The following is a description of a gene set: species: Homo sapiens Human Gene Set: E2F1DP2_01 Genes having at least one occurrence of the motif TTTSSCGC in the regions spanning 4 kb centered on their transcription starting sites. This matches the E2F1, TFDP2 transcription factor binding site V$E2F1DP2_01 (v7.4 TRANSFAC)., and this is the list of marker genes: THAP8, UNG, PAN2, TAOK2, PEG3, HNRNPUL1, MCM2, CORT, FKBP5, RET, RTBDN, GMNN, H2AC12, NELL2, SMC3 (structural maintenance of chromosomes 3), TMPO, POLE2, NFATC2IP, POLD1, GPRC5B, NOLC1, PRPS2, SOAT1, HMGXB4, IER5L, USP37, KBTBD7, RAVER1, PHF5A, PAX6, MAPK6, BRPF1, ADAMTS2, MCM3, MSH2, SYNGR4, DNAJC5G, TRMT6, OTUD7B, IPO7, MSH5, ZNF367, TBX6, NRK, DCTPP1, H3C1, E2F3, AP4M1, NASP, MCM8, CDC5L, MAP3K7, MCM6, STT3B, UBR7, PCNA, TRMT13, PCSK1, ILF3, E2F8, STAG1, MCMBP, NR6A1, DMD, POLD3, SPINK5, ARHGAP11A, PIM1, TOPBP1, PBRM1, CDCA7, PPIG, CBX3, KMT5A, ATAD2, AK2, KCNA6, ATF5, SPTB, ID3, MAZ, CAND1, DNAJC9, SASS6, MAPT, EZH2 (enhancer of zeste 2 polycomb repressive complex 2 subunit), CDK1, VCAN, YTHDC1, GABRB3, HS6ST3, EIF4A1, SNRPD1, EMSY, RASAL2, SMAD6, RPS20, RRM2, PRP4K, APH1A, PLAGL1, ZNF644 (zinc finger protein 644, NCBI Gene Id 90858), EFNA5, ALDH6A1, MXD3, ZNF524, FHOD1, ZCWPW1, SRSF1, MYH10, BRME1, NIPBL, GAPDH, ING3, NUFIP2, POLR2A, ASXL2, SMC6, FBXO5, GINS3, IL4I1, H2BC12, ZNF362, SP3, MYC, PKMYT1, GON7, NCL, UGGT1, MEPCE, MCM7, TMEM108, DNMT1, CDC25A, PPM1D, FANCG, JADE1, HNRNPA2B1, TMEM143, MRPL40, SEMA6A, RIBC1, EED, SLC9A5, SLC9A7, CASP8AP2, HMGA1, DLG3, YBX2, E2F7, HNRNPR, APPL1, TRIM39, POU4F1, TYRO3, SUMO1, HCN3, ARID4A, AP1S1, KCNS2, RPS6KA5 (NCBI Gene Id 9252), DCK, GEN1, PODN, RANBP1, CLSPN, BRMS1L (NCBI Gene Id 84312), HOXC10 (NCBI Gene Id 3226), ZNF565, ACO2 (aconitase 2), RBL1, STMN1, TFAP4, KANSL3, MTF2, PRKDC, FIZ1, ARHGAP6, EPHB1, SRSF7, FMO4, KIAA0825, GATA1, WBP2NL, CCNT1, TMEM187, ATAD5, ZNF503 (zinc finger protein 503), TRMT2A, TLE3, TRA2B, NABP2, GLRA3, ZIM2 (zinc finger imprinted 2), EMC3, WDR62, POLA1, HIRA, SMC1A, GSPT1, SLITRK4, EHBP1, POLR1G, ZBTB4 (NCBI Gene Id 57659), H2AZ2, PRPS1, PTMA, NUP62, SLCO3A1, PAQR4, CDC20B, CNOT9, FANCC, POLE4, SUV39H1, E2F1, H2AZ1, SYNCRIP, RMI2, FANCD2, PCLAF, GRIA4, GPBP1, STK35, MCM4, CTDSPL2, PCIF1, ZNF687, CDC6 (cell division cycle 6), H4C1, ILF3-DT, ZCCHC8, HNRNPD, ACBD6, LUC7L3, KBTBD6, PHC1, JADE2